The following is a description of a gene set: Mouse Gene Set: DESCARTES_ORGANOGENESIS_PRIMITIVE_ERYTHROID_LINEAGE from publication Cao J, Spielmann M, Qiu X, Huang X, Ibrahim DM, Hill AJ, Zhang F, Mundlos S, Christiansen L, Steemers FJ, Trapnell C, Shendure J (PMID 30787437) studied in species Mus musculus Mouse Organogenesis Cell Atlas (MOCA) DE_gene_main_cluster.csv, fold.change>=1.5, qval<0.05, pval<0.05, and this is the list of marker genes: Dxo, Dennd10, Cks2, Tmem14c, Sec61g, Tbc1d12, Rps2, Mki67, Prkag2, Mgst3 (NCBI Gene Id 98206), H2ac11, Pfkfb4, Knl1, Prdx6, Rpia, Vangl1 (NCBI Gene Id 229658), Stradb, Marchf5, Rpl13, Atp8a1, Adissp, Gpr146, Dusp1, Eif3d, Kel, Rangap1, Prmt3, Tuft1, Smdt1, Hmbs, Rad51b, Tspo (NCBI Gene Id 12257), Tuba1c, Ift140, Mmut (NCBI Gene Id 319389), Rmc1, Galnt10, Ano2, Fbxo9, Rhag, Pabpc4, H2-T24, Ppp1r15a, Gm28530, Gpcpd1, Gars1, Hk1 (NCBI Gene Id 15275), Trappc9, Rplp0, Grap2, Arhgap23, Ino80c, Gm13481, Trim56, Kctd9, Spty2d1, Rbks, Larp1, Selenow, Stk3, Wnk4, St3gal5, Ube2l6, Bpgm, Fam241a, Taf6l, Prokr1, Pkd2l2, Ypel4, Cdkn3, Pcx, Frat2, 1700028E10Rik, Rhd, Tal1, Hdac11, Steap3, Cit, Rhbdd1, Ndufa11, Itpripl1, Gm32051, Tango2, Fam117a, Taf10, Slc16a10, Hbb-bh0, Fbxo34 (F-box protein 34), Gmnn, Ncapd2, Arrb1, Zc3hav1, Haspin, Rpl14 (NCBI Gene Id 67115, ribosomal protein L14), Dmtn, Bsg, Abcg4, Pdxk-ps (pyridoxal (pyridoxine, vitamin B6) kinase, pseudogene), G430095P16Rik, Cntd1, Pnpo, Shpk, Mindy2, Polr1b, Art4, Slc25a39, Rfesd, Ppan, B230317F23Rik, Nrtn, Flvcr1, Suv39h1, Plek2, Ncoa4, Zfp524, Prdx2, Fzd5, Endod1, Ankrd48, Cenpb, Nuf2, Zkscan14, Rragd, Hbb-y, Cenpx, Cabin1, Ano1, Pdzk1ip1, Urod, Kif11, Cox6b2, Hsd3b6, Cpeb4, Clp1, Rabac1, Nmnat3, Tubb4b, Slc25a37, Pgp, Car2 (NCBI Gene Id 99551), Cenpe (centromere protein E), Ppm1g, Slc1a4, Golph3l, Uevld, Pop5, 1700015C17Rik, Yipf4, Gm20517, Ppox, Gm15816 (predicted gene 15816), Map2k2, Fmr1nb, Cited4, Lrrc39, Nt5c3, Chst10, Wdr91, Rad23a, Glrx5, Add1, 4930523C07Rik, Ckap2l, Taf5l, Slc39a8, Ncapg2, Epb41, Sh3yl1, Flt3l, Hdgf, Slc30a10, Samd14, Isca1, Slc38a5, Fignl1, Cenpf, Smc4, Alad, Rpl23a, Hipk1 (NCBI Gene Id 68849), Marchf2, Kif2a, Ghitm, St6galnac3 (NCBI Gene Id 20447), Evi5, 9830132P13Rik, Gm25672, A730036I17Rik, Ssx2ip, Gm20541, Marchf3, Nudt4, Ddx27, Gm14066, Dlg1, Rpsa, Ston2, Ndufb9, H2bc11, Abhd4, Zfpm1, Ddhd1, Pet100, Pip5k1b (NCBI Gene Id 53355), Tmem131, Kif14, Hba-a2, Fech, 1110059G10Rik, Sri, Rpl3, Tnrc6b, Tinagl1, Aspm, Nusap1, Htatip2, Gypc, Gtpbp2, Diaph3, Otud5, Ell2, Bysl, Ucp2, Irs2, Gm3793, Acot11, Ppp1r9b, Dhh, Gm15345, Tmem86b, D030028A08Rik, Iars1, Cyb5a, Lcmt2, Ankrd54, Noc2l, Iars2, Acp5, Cat, Alas2, Gm2788, Tmem184a, Tpx2, Slc4a1, Eif3f, Pip4k2c, Hesx1, Tgm2, Cdca8, Grina, Tspan32, Mpv17l2 (NCBI Gene Id 234384), Rnf212, Cdkn2c, Anln, Slc20a1, Top2a (NCBI Gene Id 21973), Smg5, Ninl, Mrpl51, Epor, Gypa, Ank1, Rusf1, Cd59a, Babam2, Trib3, Ogdh, Pitrm1, Gps2, Klf1, Abcg2, Retreg2 (NCBI Gene Id 227298), Frs2 (NCBI Gene Id 327826), Mrap, Slc52a3, Taf9, Aqp3, Exoc6, Eif2b3 (eukaryotic translation initiation factor 2B, subunit 3), Cd59b, Aldh9a1, Maz, Rad18, Pabpc1, Dlgap5, Capn5, Cox17, Arid3a, Erfe, Slc30a1, Spta1, Trim58, Hbb-bt, Rpl8, Gcnt1, Gmpr, Agpat4, Pik3cb, Atg4d, Skic2, Afg3l2, Reep6, Ccnb2, Wars1, Rmdn3, Pdk2, Anp32b, mt-Nd2, Brca2, H2ax, Nans, Nanp, Tatdn3, Liph, Zpr1, Hras, Tmod1, Acp1, Cited2, Svip, Ccnd3, Rexo2, Cenpl, H1f4, Mpp2, Nt5dc2, Slc9a8, Gm10390, Slc26a2, Nsl1, Fam210b, Dyrk3, Ogfrl1, Ankle1, Kifc5b, Cops6, Cdr2, Tmc8, Asb17 (NCBI Gene Id 66772), Gata1, Gpx1, Ptp4a3, Akap7, Ndufs3, Btrc, Icam4, Fth1, Uros, Asb17os, Gpn3, Gclm, Slc25a21, Myc, Mfap1b, Pkhd1l1, mt-Nd5, Trim10, E2f2, Ndc80, Mul1, Pfkfb1, Slc22a4, Lbr, Mrm1, Prdx2-ps1, Ncf4, Mthfd2, 9830144P21Rik, Nsmaf, Ankrd9, Tspan33, Azin1, Mtm1, Psme3, Rpl37, Cox6a1, Pdik1l, Med13l, Tnfrsf21, 1700112D23Rik, Eipr1, Pabir1, Chrac1, Nptn, mt-Cytb, Ackr3, Wdr81, Pde10a, Nars1, Ccrl2, Inhca, Creg1, Hace1, Asb1, Cep70, Gm42047, Dapk2, Aco2, Brpf3, Ftl1, Wdr83os, Tmc6, Ccdc92b, Ehd1, Dph2, Shld1, Pfkfb2, Mthfr, Fads3, Epb42, Gm29724, Chac2 (ChaC, cation transport regulator 2), Clk3, Snca, Trak2, Rps11, Ptpmt1, Jak2, Gm867 (NCBI Gene Id 633962), Fryl (FRY like transcription coactivator), Mrpl35, Eif2ak1, Dhrs13, Psenen, Cmpk2, Slc43a1, Rec114, Il4i1, 1810053B23Rik, Micall2, Mybbp1a, Smg9, Cnppd1, Arrdc2, Nfu1, Ddrgk1, Arf5, Sptb, Hmmr, Gm14049, Aqp8, Lyset, Akip1, Wdr26, mt-Nd4, Slc6a9, Bmp2k, Ifi35, Ttc39aos1, Hba-a1, mt-Co1 (NCBI Gene Id 99197), Ier3, St3gal6, Gadd45a, Prxl2a, Mcmdc2, Serinc3, Rnf10, Spns2, Hba-x, Il1bos, 4933401H06Rik, Gm23127, Cpox, Pak1ip1, Atf4, Katnb1, Smim1, Otub2 (OTU domain, ubiquitin aldehyde binding 2), Apeh, Ttc39a, Tmem147, Gsr, Ogfod2, Xk, Gm2061, Shmt2, Sgk3, Telo2, Hipk2, Pigq, Gnrh1, Josd2, Gm37249, Piezo1 (piezo-type mechanosensitive ion channel component 1), Myo15a, Gm17276, Ermap, Snx15, Asns, Ccdc71l, 9630028B13Rik, Gm16867 (predicted gene, 16867), Hspa12b, Fam169a, Lpcat1, Ache, Cimap2, Adra2b, Ttf2, Gins3, 2410003L11Rik, Csf2rb, Dennd2c, Uba7, Pim1, Frrs1 (ferric-chelate reductase 1), Cish, 6530413G14Rik, Slc43a3 (solute carrier family 43, member 3), Kif18b, Nop9, Tent5c, Ncoa7, Hemgn, Klhdc2, Dhrs11, Slc23a2, Abcb10, 1300002E11Rik, Tmem238, Tfrc, Ypel5, Rps10, Hbb-bh1, Csf2rb2, mt-Nd1, Gm22247